The following is a description of a gene set: studied in species Homo sapiens Any process that results in a change in state or activity of a cell or an organism (in terms of movement, secretion, enzyme production, gene expression, etc.) as a result of a UV-B radiation stimulus. UV-B radiation (UV-B light) spans the wavelengths 280 to 315 nm. Human Gene Set: GOBP_RESPONSE_TO_UV_B, and this is the list of marker genes: MAP3K20, HYAL3, HMGN1, ERCC6, MSH2, IL12B, CRIP1, NLRP1, CDKN1A, HYAL2, RELA, XPC (XPC complex subunit, DNA damage recognition and repair factor), MFAP4, MME, BCL2, STK11, IL12A, HYAL1, MAPK11, MAPK14 (mitogen-activated protein kinase 14), IVL (NCBI Gene Id 3713)